The following is a description of a gene set: from publication Kurokawa Y, Matoba R, Takemasa I, Nagano H, Dono K, Nakamori S, Umeshita K, Sakon M, Ueno N, Oba S, Ishii S, Kato K, Monden M (PMID 15288478) BACKGROUND/AIMS: Hepatocellular carcinoma (HCC) has a very poor prognosis, due to the high incidence of tumor recurrence. As the current morphological indicators are often insufficient for therapeutic decisions, we sought to identify additional biologic indicators for early recurrence. METHODS: We analyzed gene expression using a PCR-based array of genes in 100 HCC patients. Informative genes predicting early intrahepatic recurrence were selected by random permutation testing, and a weighted voting prediction method was constructed. Following estimation of prediction accuracy, a multivariate Cox analysis was performed. RESULTS: By permutation testing, we selected genes demonstrated distinct expression patterns differing significantly between recurrence cases and recurrence-free cases. Our prediction method, using the 20 top-ranked genes, correctly predicted the early intrahepatic recurrence for 29 of 40 cases within the validation group, and the odds ratio was 6.8 (95%CI 1.7-27.5, P = 0.010). The 2-year recurrence rates in the patients with the good signature and those with the poor signature were 29.4 and 73.9%, respectively. Multivariate Cox analysis revealed that molecular-signature was an independent indicator for recurrence (hazard ratio 3.82, 95%CI 1.44-10.10, P = 0.007). CONCLUSIONS: Our molecular-based prediction method using genes is clinically useful to predict early recurrence of HCC. Human Gene Set: KUROKAWA_LIVER_CANCER_EARLY_RECURRENCE_UP studied in species Homo sapiens Genes up-regulated in hepatocellular carcinoma (HCC) with early recurrence., and this is the list of marker genes: NRG2, HSPA1A, NMT1, USP39 (NCBI Gene Id 10713), CDH1, RGS5, DAPK1, ALCAM, KRT8, AK1, PUF60, DDX39B